The following is a description of a gene set: Human Gene Set: GOMF_LAMININ_1_BINDING Binding to laminin-1, a glycoprotein trimer with the subunit composition alpha1, beta1, gamma1. studied in species Homo sapiens, and this is the list of marker genes: NTN4, LACRT, SLIT2, SHH, DAG1 (NCBI Gene Id 1605, dystroglycan 1), NID1, PXDN